The following is a description of a gene set: species: Homo sapiens A protein activation cascade that contributes to blood coagulation and consists of the interactions among high molecular weight kininogen, prekallikrein, and factor XII that lead to the activation of clotting factor X. Human Gene Set: GOBP_BLOOD_COAGULATION_INTRINSIC_PATHWAY, and this is the list of marker genes: F12, F8, FLNA, APOH, GP1BA (glycoprotein Ib platelet subunit alpha), GP9, GP1BB, GP5